Given this list of marker genes TRAPPC2L, TRAPPC6B, TRAPPC10, TRAPPC2, TRAPPC13, TRAPPC14 (trafficking protein particle complex subunit 14), TRAPPC1, TRAPPC4, TRAPPC9, TRAPPC2B, TRAPPC5, TRAPPC3, here is a description of the gene set: A complex that mediates intra-Golgi traffic, Golgi exit, endosome-to-Golgi traffic, and the trafficking of autophagy proteins from Golgi to the phagophore assembly site. Binds to a component of the COPI coat. In yeast it includes the following subunits: Bet3 (as homodimer), Bet5, Tca17, Trs20, Trs23, Trs31, Trs33, Trs65, Trs120, Trs130. The whole complex is thought to dimerize with itself. Human Gene Set: GOCC_TRAPPII_PROTEIN_COMPLEX species: Homo sapiens